The following is a description of a gene set: Any process that results in a change in state or activity of a cell or an organism (in terms of movement, secretion, enzyme production, gene expression, etc.) as a result of a stimulus by the chemical structure of the anion portion of a dissociated acid (rather than the acid acting as a proton donor). The acid chemical may be in gaseous, liquid or solid form. Mouse Gene Set: GOBP_RESPONSE_TO_ACID_CHEMICAL species: Mus musculus, and this is the list of marker genes: Mir539, Hcn1, Dnmt3a, Gria2 (NCBI Gene Id 14800), Nfat5, Avpr1a, Gprc6a, Klf2, Cdh1, Mir1983, Umod, Naip2, Rela, Mirlet7f-1, Ccl2, Fyn, Mir466f-1, Kcnb1, Mir34a, Mir203, Nqo1, Lamtor4, Lamtor2, Edn1, Mir496a, Mirlet7d, F7, Mir30e, Rragd (Ras-related GTP binding D), Lars1, S100a10, Gdf10, Mir183, Cfl1, Rbx1-ps, Rragc, Tomm70a, Glra1, Lamtor3, Pdgfra, Mir92b, Gip, Plec (plectin), Krt8, Bdnf, Spaar, Mir451a, Mir466g (NCBI Gene Id 100124495), Hnf1a, Mir101a, Mir487b, Mirlet7i, Bcl2l2, Mir654, Socs1, Amigo1, Mir378a, Mir145a, Mir92-2, Mir221, Rbx1 (NCBI Gene Id 80401), Mir107, Ufl1, Prkn, Grin1, Pck1, Grin3b, H2bc1, Agap2, Mir365-2 (microRNA 365-2), Lyn, Slc1a2, Tmbim6, Col4a1, Mir342, Col1a2, Pkd2, Glra3, Capn2, Mir301, Atp1a3, Casp3, Mir1897, Cpeb4, Mtor (mechanistic target of rapamycin kinase), Pdx1, Stambpl1, Mir466f-3, Mir669f, Hnrnpd (heterogeneous nuclear ribonucleoprotein D), Ptgs2, Npas4, Ngf, Lamtor5, Mir369, Mmp3, Col5a2, Mir409, Mir130a, Neurl1a, Mir376c, Slc7a5, Pdgfd, Mir346, Cul3, Slc1a3, Mir382, Mir191, Mir429, Mir15a, Rps6kb1, Cebpb, Eif2s1, Mir425, Mir103-2, Sesn3, Ces2c, Bcl2l1, Aifm1, Mir486, Mir199a-1, Mmp2, Mir379, Xbp1, Mir872, Mir194-1, Abcb1a, Lmnb1, Mir1948, Ubr1, Alad, Mir667, Sesn1, Castor1, Mirlet7f-2, Mir495, Mir1224 (NCBI Gene Id 100316739), Mir27a, Bmt2, Col4a6, Ntrk2 (neurotrophic tyrosine kinase, receptor, type 2), Mir29c, Pik3ca, Vegfa, Mir376a, Col3a1, Hsf1, Mir137, Mir217, Rragb, Cdo1, Mir466f-2, Mir30a, Bcl2, Mir802, Klhl22, Mir455, Cdkn1b, Lrrc25, Sst, Gclc, Mir466i, Mir30d, Mir543, Mir192, Ep300, Mir351, Mir194-2, Pdgfc, Mir154, Tomm20, Tnf, Mir376b, Mir23a, Gstp1, Rraga, Pkd2l1, Aqp2, Mir544, Meak7, Egfr, Ppp1r9b, Mir199a-2, Ntrk1, Asns, Pcna, Atp7a, Castor2, Mir222, Mir1894, Mir103-1 (NCBI Gene Id 723824, microRNA 103-1), Mir421, Gria1, Mir466h, Anxa2, Mir466j, Mat2a, Mir666, Mir3072, Ass1, Hmgcs2, Mir99a, Cpeb1, Mir365-1, Ubr2 (ubiquitin protein ligase E3 component n-recognin 2), Mir377, Slc38a9, Eno1, Mir150, Mir122, Mir214, Mir101b, Mir216b, Baiap2, Mir24-2, Col16a1, Igf1r, Mir669c, Mir193a, Atp2b4, Myd88, Mirlet7a-1, Cpeb3, Lrp11, Ghsr, Mir200c, Nsmf, Mir151, Gmps, Crls1, Mir134, Rptor, Mir708, Nfe2l2, Gclm, Tuba1a, Lamtor1, Dnmt3b, Mir155, Cps1 (NCBI Gene Id 28143), Zeb1, Mir22, Mir15b, Cybb, Mir674, Grin2a, Sipa1, Hpca, Sh3bp4, Sesn2, Mir466f-4, Mir200b, Mir762, Grin2d, Prmt1, Mir676, Ipo5, Glra4, Col6a1, Mir92-1, Mir224, Col1a1, Six1, Mirlet7a-2, Mir31, Dnmt1, Glra2, Slco1b2